The following is a description of a gene set: Any process involved in the maintenance of an internal steady state of calcium ions within the endoplasmic reticulum of a cell or between the endoplasmic reticulum and its surroundings. Mouse Gene Set: GOBP_ENDOPLASMIC_RETICULUM_CALCIUM_ION_HOMEOSTASIS species: Mus musculus, and this is the list of marker genes: Tgm2, Bcl2, Bak1, Tmtc4, Atp2a3, Itpr1, Grina, Bax, Wfs1, Pacs2, Psen1, Psen2, App, Tmbim6, Tmco1, Atp2a1, Herpud1, Clcc1, Ccdc47, Tunar, Selenok, Pml, Thada (thyroid adenoma associated), Camk2d, Kctd17, Rap1gds1, Dmtn, Atp2a2